Given this list of marker genes LIG1, GINS3, RTF2, ZMPSTE24, FEN1, TERF1, GINS1, AICDA, E2F7, TK1, DBF4B, WIZ, E2F8, BLM, GMNN, DBF4, FBXO5, CDC7, CDT1, FGFR1, WRN, DACH1, ATAD5, MCM3, UPF1, TIPIN, BCL6, DONSON, SENP2, MCM2, ATRX, MCM4, DNA2, POLA1, RTEL1, PCNA, RPA4, RECQL5 (RecQ like helicase 5), BRCA2, MCM6, ZPR1, CDC45, INO80, ZNF830, RAD51, TERF2, NUGGC, here is a description of the gene set: Human Gene Set: GOBP_CELL_CYCLE_DNA_REPLICATION The DNA-dependent DNA replication that takes place as part of the cell cycle. studied in species Homo sapiens